The following is a description of a gene set: from publication Chen Y, Wang X (PMID 31504780) Mouse Gene Set: MIR_326_3P Genes predicted to be targets of miRBase v22 microRNA mmu_miR_326_3p in miRDB v6.0 with MirTarget v4 prediction scores > 80 (high confidence targets). studied in species Mus musculus, and this is the list of marker genes: Usb1, Zfp362, Igdcc3, Dicer1, Palm (NCBI Gene Id 18483), Cdh8, Slc19a2, Tor4a, Fam163a, Ubiad1, Ccdc7b, Fbxl16, Wnt8b, Arhgap36, Ppp2r5b, Sh2d1b1, Fbxl14, Bclaf1, Tex13b, Rtl5, Tnks2, Snph, Pacc1, Parva, Mmp13, Ralgapa1, Abcg1, Tspan18, Lrrc3, Ptpn3, Zmiz1, Itga5, Gpr19, Afdn, Mrpl35, Trabd2b, Nlk, Wnt9b, Dact2, Cpsf7, Spock1, Scd1, Dhx33, Glod5, Npas3, Vldlr, St3gal3, Atg16l1, Acrbp, Plekhd1, Mief2, Ces1a, Ppt2, C2cd2, Ubxn10, Oxsr1, Tnc, Rfng, Gpx7, Erbb4, Glra1, Cgnl1, Rcor1, Gpd2, Cd47, Tln1, Rbbp4, Arid5a, Os9, Usp2, Grpel2, Zfp609, Sec14l1, Ppp1r3f, Rnf185, Epha3, Mtcl2, Ucn2, Tomm34, Fgf11, Cnnm1, Rpusd3, Abcc1, Lrrc15, Zzef1, Hip1, Bhlhe40, Rarres2, Ncan, Lrtm2 (NCBI Gene Id 211187), Alad, Gpd1, Zfp322a, Plec, Clcn4, Celf5, Phka1, Klk5, Atf6, Epb41l1, Fndc7, Nfasc, Zc3h10, Sh3bgr, Wdr76, Rem2, Acsf2, Mfsd9, Scfd2, Slc5a3, Cbfa2t3, Prkcb, Prss35, Ccdc127, Mief1, Gsk3b, Nos1, AI467606, Ggt7, Ets1, Pla2g4f, Cherp, Cyb5rl, Agbl3, Dag1, Iqsec3, Metap1, Kif9, Scn2b, Arpp21, Tfg, Zfp422, Lrrtm1, Nhs, Chrm1, Brpf3, Emilin3, Ralgapa2, Fam168a